The following is a description of a gene set: Mouse Gene Set: TOX3_TARGET_GENES Genes containing one or more binding sites for (Tox3) in their promoter regions (TSS -1000,+100 bp) as identified by GTRD version 20.06 ChIP-seq harmonization. from publication Yevshin I, Sharipov R, Kolmykov S, Kondrakhin Y, Kolpakov F (PMID 30445619) studied in species Mus musculus, and this is the list of marker genes: Slc66a3, Glt8d2 (NCBI Gene Id 74782), Abhd17b, Vapa, Sgms1, Nbeal1, Gm20033, Snn, 4930579D09Rik, Resf1, Pcbp3, Tle1, Spry2, Mpv17l2, Rnf38, Ptprs, Bcl2l11, Mir7671, Nmt2, Lrrc20, Map4k4, Acsl3, Jak2, Cic, Socs3, Gpx4, Litaf, Pik3r3, Cobll1, 9330111N05Rik, Epb41l1, Dlx1, C630043F03Rik, Ubald2, Chka, Gm7160, Zyx, C230096K16Rik (NCBI Gene Id 414098), Sspn, Mex3c, Pdia4, Utp14b, Pgp, Agpat3, Suco, 9430007M09Rik, Klf3, Gm13594, Map4, Klf9, Zcchc2, Cav2, Iqsec1, Trib1, Micall1, Brpf1, Zfand5, Gm10463, Dusp1, Tatdn2, 1110059E24Rik, Tspyl2, Rnf13, Azin1 (NCBI Gene Id 73525), Nemp1, Myh9, Gata2, Ets1, Shisa4, Gfra1, Tlnrd1, Gsk3b, Fam117b, Itgb4, Abr, Nab2, Cdc42ep1, Zfp36l2, Hmgcr, Mesd